Given this list of marker genes Mup4, Adrb2, Ednrb, Mup5, Ccr5, Tnfrsf11a, Apln, Tnfsf11, Adrb3, Il1b, Mup2 (NCBI Gene Id 17841), Adrb1, Ccl5, Ptgs2, Arrdc3, Slc27a1 (solute carrier family 27 (fatty acid transporter), member 1), Tnf, Il1a, Abat, Mup11, Ptges, Nmu, Trpv1, Mup1, Il1rn, Ptger3, Mup3, Cnr1, Htr2a, here is a description of the gene set: species: Mus musculus Any homeostatic process in which an organism produces heat, thereby raising its internal temperature. Mouse Gene Set: GOBP_HEAT_GENERATION